Given this list of marker genes SCN5A, RNF2, GTF2IRD2, CLIC2, PRG4 (proteoglycan 4), ZIC3, TBX5, BAZ1B, MYPN, MEFV, FBN2, CCR1, ZMPSTE24, RPS6KA3, WDR37, MTX2, NCAPG2, LDLRAP1, ADNP, SMAD6, APOB, SKI (NCBI Gene Id 6497), BANF1, PYROXD1, NDUFB11, LRPPRC, IL10, TNNT2 (NCBI Gene Id 7139), ARSB, MLXIPL, XYLT2, IL12A, FKBP14, COX7B, PEX2, FNIP1, EIF4H, ERAP1, STAT4, SLC22A5, FAS, CHST14, GBA1, VPS33A, THSD1, ADAMTS17, RFC2, B3GALT6, SMAD3, MAPK1, CTCF, VPS37D, PRKAR1A, CHST3, MYH7, COX6B1, CITED2, COL5A1, HAAO, HEXB, WBP4, ADAMTS19 (NCBI Gene Id 171019), GATA4, PPP1R13L, DCHS1, IL23R, HADHA, PDSS1, METTL27, MYL2 (NCBI Gene Id 4633), IDUA, IRX5, GTF2I, PPP1CB, ADAMTS10, HCCS, ZNF148, ERI1, FHL1, POLG, ALPK3, SGO1, KLHL24, AGR2, NOTCH2, FHOD3 (NCBI Gene Id 80247), NCF1, COA6, DTNA, GATA6, UBAC2, SCN4A, KLRC4, IFT56, C4A, NEK1, ADAMTSL2, TLR4, IL6ST, DNMT3A, SYT2, RSPRY1, SPEG, MYSM1, TNNC2, RAD21 (NCBI Gene Id 5885), ALDH18A1, MEGF8, GJA1, UBE2A, ABCG5, NKX2-5, CCND2, RPL5, AKT3, TWNK, DLL4, GLB1, FLNC, FKBP6, BAG3, TXNDC15, ARL6, KDM6A, MCTP2, LDLR, ABCC6, NOTCH1, NF1, SMAD4, ANKRD11, DVL3, TBX20, HLA-B, SLC31A1, NONO (NCBI Gene Id 8253), FLNA, NKAP, LIMK1, TLR7, G6PC3, DZIP1, SLC25A24, AIP, COL1A1, ATRX, GPR101, RPL3L, LZTR1, CDH2, FBN1, COL1A2, GNPTAB, GLA, GTF2IRD1, LMNA, CRYAB, ALG9, SDHD, TGFB3, GNS, ABCG8, PRDM16, PCSK9, PIK3R2, ADA2, CSGALNACT1, TNNI3 (NCBI Gene Id 7137), MYH6 (NCBI Gene Id 4624), IL12A-AS1, EXOSC5, AHDC1, TMEM270, LTBP2, MAP3K7, RPS19, HGD, MYCN, FBLN5, CLIP2, KIF20A, TLL1, BUD23, SOX5, LOX, TAFAZZIN, LMOD2, RAF1, ESAM, DOHH, XYLT1, ELN, HADHB, EFEMP2, PKD1, STX1A, CBL, RIT1, PLD1 (phospholipase D1), TBL2, KMT2D, IFNGR1, DSE, ACTC1, LTBP3, DNAJC30, AGA, ATP6V1E1, MAN2B1, HEPHL1, TPM1, ATP6AP1, COL5A2, here is a description of the gene set: Human Gene Set: HP_ABNORMAL_ATRIOVENTRICULAR_VALVE_PHYSIOLOGY Abnormal atrioventricular valve physiology Any functional defect of the mitral or tricuspid valve. species: Homo sapiens